The following is a description of a gene set: Any process that reduces the pH of the lysosomal lumen, measured by the concentration of the hydrogen ion. Human Gene Set: GOBP_LYSOSOMAL_LUMEN_ACIDIFICATION studied in species Homo sapiens, and this is the list of marker genes: SNAPIN, ATP6AP1, ATP6V0A1, ATP6V1A (ATPase H+ transporting V1 subunit A), CLN5, TCIRG1, CREG1, ATP6AP2, TMEM106B, RNASEK, ATP6V0B, TMEM199, ATP6V1D, GRN (granulin precursor), CLN6, ATP6V0C, LAMP2, TMEM9, CLN3, ATP6V1F, CCDC115, LAMP1, PPT1, ATP6V1H